Given this list of marker genes SYNGAP1, HECW2, CUX2, NOVA2, HNRNPH2, SLC4A10, GRIK2, FMR1, NAA20, PRKAR1B (protein kinase cAMP-dependent type I regulatory subunit beta), ASXL3, PDZD8, DHPS, GABBR2, AFF2, TAF4, CIC, NEXMIF, CHD8, CCNK, TRAPPC6B, TRAPPC9, KMT5B, OCA2, CSNK2A1, HERC2, BCL11A, UBE3A, CDK19, MBD5, here is a description of the gene set: Human Gene Set: HP_RECURRENT_HAND_FLAPPING A type of repetitive behavior in which the affected individual repeatedly waves the hands and/or arms rhythmically. studied in species Homo sapiens Recurrent hand flapping